The following is a description of a gene set: studied in species Homo sapiens This term refers to a phenotypic feature that was first observed prior to birth during the second trimester, which comprises the range of gestational ages from 14 0/7 weeks to 27 6/7 (inclusive). Human Gene Set: HP_SECOND_TRIMESTER_ONSET Second trimester onset, and this is the list of marker genes: CREB3L1, SCN4A, IFNG, GFRA1, CCDC88C, ERCC5, MDFIC, RAB34, L1CAM, TXNDC15, BMPER, GRIP1, SCN5A, LMOD1, SRPK3, SLC25A19 (NCBI Gene Id 60386), ALPK3, SIN3A, TSC2, B4GAT1, PLXND1, FGFR3, FH, DEPDC5, RMRP, ESAM, RECQL4, STRA6, KDM6A, KIF14, THSD1, COL2A1, WT1, ADGRG6, MYRF, KMT2D, IARS1, NDUFB7, NEK8, NUP88, ROBO1 (roundabout guidance receptor 1), TBXT, BRD4, ACTA1, TBX5, PPIB, SC5D, MKS1, COASY, TCTN3, BICD2, TRIP11